Given this list of marker genes Depdc1a, Gm5983, Wls, Mir186, Ankrd13c, 4930566N20Rik, Erich3, Cryz, Fpgt, Gm43526, Gm20752, Gm42946, Lrriq3, Gm24373, Gm6520, Scp2-ps1, Gm18589, Gm15577, 4930592C13Rik, Gm15578, Lrrc40, Cth, Gm23379, Lrrc7, Gm6510, Gm23038, Ptger3, Tnni3k, Gm20389, 1810013D15Rik, Gm9423, 9330178D15Rik, AI606473, Gm5550, Rpe65, Lhx8, Tyw3, Zranb2, Gm23941, Gm33466, 4930570G19Rik, Gm5285, Srsf11, Negr1, here is a description of the gene set: studied in species Mus musculus Mouse Gene Set: chr3H4